The following is a description of a gene set: Any process that activates or increases the frequency, rate or extent of synaptic vesicle fusion to the presynaptic membrane. species: Homo sapiens Human Gene Set: GOBP_POSITIVE_REGULATION_OF_SYNAPTIC_VESICLE_FUSION_TO_PRESYNAPTIC_ACTIVE_ZONE_MEMBRANE, and this is the list of marker genes: PRRT2, ERC2, DOC2A, SYT7, SYT2, DOC2B, SYT4, SYT9, SYT1, SYT13, SYT8, RPH3A, SYT11, RPH3AL, SYT5